Given this list of marker genes Cd24a (NCBI Gene Id 12484), Erbin, Gstp2, Gstp1, Gstp-ps, Gstp3, Apod, C1qtnf3, Nr1h4, Socs5, here is a description of the gene set: Any process that stops, prevents, or reduces the frequency, rate, or extent of production of monocyte chemotactic protein-1. Mouse Gene Set: GOBP_NEGATIVE_REGULATION_OF_MONOCYTE_CHEMOTACTIC_PROTEIN_1_PRODUCTION species: Mus musculus